The following is a description of a gene set: Human Gene Set: MIR5003_3P from publication Chen Y, Wang X (PMID 31504780) species: Homo sapiens Genes predicted to be targets of miRBase v22 microRNA hsa-miR-5003-3p in miRDB v6.0 with MirTarget v4 prediction scores > 80 (high confidence targets)., and this is the list of marker genes: RHOXF2B, CALD1, ENKUR, CDON, MAP3K2, ADAT2, SPRED1, RFX3, COG6, RDM1, FGD5, HSF5, KIF11, SHFL, PIAS1, SLC7A7, CRISPLD1, GREB1, NR2C2, TMEM168, MAGI1, BEND4, SBF2, KIT, PURA, CYP1B1, MLLT10, TMPO, RIMS2, PTPN22, NDN, C2orf69 (chromosome 2 open reading frame 69), TAB2, ATP8B1, TBP, PRPF39, ZDHHC2, FGF12, KLHL24, ROBO1, MCFD2, KLHL9, MYT1, BACH2, MFSD6, MAGI3, AP5M1, NUP50, ACBD7, PRDM12, UBE2H, FIP1L1, CDH1, C11orf58, ZC3H12C, SNIP1 (Smad nuclear interacting protein 1), TMEM245, DRD1, MAT2B, SMTNL2, ELAVL2, JAG1, CREBL2 (NCBI Gene Id 1389), LRRIQ3, SSBP2 (single stranded DNA binding protein 2), PGRMC1, DHFR2, CPNE3, NEXMIF, SBNO1, TAFA2, TMEM47 (transmembrane protein 47), DCAF12L1, CTXN3, EIF4G3, ROBO2, MCTP1, GBP7, USP27X, NID1, YY1, MARCKS, CADM2, PDK3, EDN1, PRKAB2, SAXO2, MON2, SLC6A5, ADCYAP1, KDM6A, LASP1, DAZ2, XPR1, OTUD6B, CNKSR2, CDH8, ZCCHC4, MAB21L1 (mab-21 like 1), IMPACT, ANK2, CIPC, ANKRD34B, TRA2B, PHIP, TRIM59, MSL2, CD2AP, SLC7A11, ADAMTS5, CLDN12 (claudin 12), STIM2 (NCBI Gene Id 57620, stromal interaction molecule 2), IFIT5, TMIGD1, SNX5, TMEM170B, NETO1, SEMA3D, RAB11FIP2, FBXO11, TRAPPC11, IPO5, ARHGEF4, ZNF385B, RAB21, C17orf78 (NCBI Gene Id 284099), PORCN, SLC4A5, WWC2, AGMO, CILK1, NDUFB6, CSMD3, PDS5A, KCNK6, NF1, COL4A4, CDH13, MOSPD2, PPP2R3A, CCDC25, SCN7A, IL17B, SYT4, BRWD1, RPN2, TMEM33, FOXJ1, CREM, ADAMTS6, MRTFB, CNTN3, KLF12 (KLF transcription factor 12), DMTF1, SMLR1, CDK12, GLI2, CXADR, NEUROD1, ZNF257, RNASEH2B, DCP1B, ZNF367, RGS7BP, BHMT, NHS, SH3BGRL2, GLS (glutaminase), CACNA2D1, RNF217, BCL11B, KLHL11, PLEKHH1, RAVER2, CGRRF1, TMEM100, RNF180, PTGR3, CAPZA2, TTC28, STARD13, TUBA1A, FZD3, MBLAC2, CREBZF, ALG14, TENM1, TMEFF1, YWHAQ, GALNT6, SLC44A1, BEND2, ZCCHC8, MED13, RAB30, SSX2IP, ANLN, CCDC82, ATP6V1G1, ELP5, HSP90AA1, WDR26 (WD repeat domain 26), TSFM, FBXO32, LUC7L3, SMG7, STRIP2, MRFAP1, ZNF235, CLUAP1, ZNF714, ZNF131, RHOXF2, ZNF614, ATG3, ATRN, RBM44, PPP1R3C (protein phosphatase 1 regulatory subunit 3C), ATP11B, LARS1, HMGB1, KCND2, PAFAH1B1, FBXO34, PCDH15, NEDD4, LAMC1, SP4, MRPL50, RND3, FBXO45, GORAB, PUM2, NRIP1, PCSK6, DMXL1, SERPINI1, ZNF680, HSDL2, ALG10B, SLC7A14, KMT5B, GTF2H1, LYRM1, ARRDC3, CREB1, ZBTB10, CERT1, KDM5A, OGN, CHST6, NUFIP2, ARL5A, INTS6, ITGA6, RBMXL2, ZNF182, NR2E1, ZFX, AFG1L, ERG28, MBTPS2, SLITRK4, A1CF, TRIM71, LSM11, PHC3, UBL4B (NCBI Gene Id 164153), POMP, THUMPD1, TBX22, ALG11, SLC16A1, CUL4B, SHISA6, GPM6A, RC3H1, ACVR2B, VASH2, GRPR, ORC4, BRWD3, ASAH1, CBL, HYDIN, PAPPA2, ZZZ3, CLOCK, TMEM242, CSNK1G3, VGLL3, FAM120C, TTI1, UBXN4, NANOS1, PURG, CNKSR3 (CNKSR family member 3), CD226, ADAMTS18, QSER1, ZBBX, ZFP36L2, LPP, TRPC5, SS18L1, CCDC88A, NLGN4Y, ACSM2A, ELMOD2, YRDC, S1PR3, PCGF5, NAV3 (NCBI Gene Id 89795), DHFR (dihydrofolate reductase), GGPS1, TMTC3, MARCHF5, LYSMD3, RPGRIP1L, COL5A1, FYTTD1, PNMA1, CDC42, GSK3B, NABP1, USP46, PECR, TARDBP, RBM15, IYD, USP53 (ubiquitin specific peptidase 53), MSANTD3-TMEFF1